Given this list of marker genes Wnt4, Il1a, Sec14l2, Npy1r, Ppargc1a (NCBI Gene Id 320239), Tnf, Bmp6, Abcg4, Nr1d1, Gnai1, Fdps, Abcg1, Adora2b, Srebf2, Nr5a2, Igf1r, Dab2, Prkaca, Scp2, Igf2, Scap, Star, Fgf1, Igf1, Fshb, Cga, Gh, Por, Mapk1, Ifng, Cyp7a1, Cyp17a1 (cytochrome P450, family 17, subfamily a, polypeptide 1), Paqr3, Srebf1, Stard4, Qki, Mbtps2, here is a description of the gene set: Mouse Gene Set: GOBP_POSITIVE_REGULATION_OF_STEROID_BIOSYNTHETIC_PROCESS species: Mus musculus Any process that increases the frequency, rate or extent of the chemical reactions and pathways resulting in the formation of steroids, compounds with a 1,2,cyclopentanoperhydrophenanthrene nucleus.